The following is a description of a gene set: species: Homo sapiens Human Gene Set: GOBP_REGULATION_OF_PHOSPHOLIPID_TRANSLOCATION Any process that modulates the frequency, rate or extent of the translocation, or flipping, of phospholipid molecules from one monolayer of a membrane bilayer to the opposite monolayer., and this is the list of marker genes: ABCB4, TMEM30A, ATP8A1, FASLG, ATP8A2, XRCC4